The following is a description of a gene set: TREK1 and TREK 2 are activated by physiochemical changes like stretch, convex deformation of the plasma membrane, depolarization, heat and intracellular acidosis. Polyunsaturated fatty acids (PUFA) including arachidonic acid open TREK channels. part of: Tandem pore domain potassium channels Reactome Pathway: TWIK related potassium channel (TREK) studied in species Homo sapiens, and this is the list of marker genes: KCNK10, KCNK4, KCNK2